Given this list of marker genes ASPM, CENPF (NCBI Gene Id 51468), NSD2, CDC20, HMGB2, UBE2S, ZWINT, TMPO, RRM2, CCNF, DLGAP5, H2AX, BIRC5, PCNA, CDCA8, CENPE, PRC1, NUSAP1, MCM2, CDK1, RRM1 (NCBI Gene Id 6240), SHCBP1, SMC4 (structural maintenance of chromosomes 4), KIF18B, AURKA, TYMS, PTTG1, CCNA2, CCNB2, DNAJC9, FOXM1, here is a description of the gene set: Neighborhood of H2AFX H2A histone family, member X in the GNF2 expression compendium studied in species Homo sapiens Human Gene Set: GNF2_H2AFX Neighborhood of H2AFX